The following is a description of a gene set: studied in species Homo sapiens from publication Chen Y, Wang X (PMID 31504780) Genes predicted to be targets of miRBase v22 microRNA hsa-miR-5008-5p in miRDB v6.0 with MirTarget v4 prediction scores > 80 (high confidence targets). Human Gene Set: MIR5008_5P, and this is the list of marker genes: C12orf42, ARHGAP27, ARFGEF1, PLAUR, URM1, EPB41L1, FOS, APOBR, ATXN1L, MAN1C1, PIK3C2G, KAZN, NRIP2, ALS2CL, BCL11B, FAM234A, FBXO10, CPNE5, RTP2, FOXJ2, ITPKB, ITIH4, RBM15, PRPF19, ZNF236, LUZP1, SMPD3, CDH13, NTSR1, RPS6KL1, SNX27, CTDSP2 (CTD small phosphatase 2), ATXN7, CERS2, TMCO1, JAK3, MIGA2, MYL3, HIF3A, ARRB1, DOK7, PDE2A, ABTB2, FGF12, APOBEC3D, AGAP1, CLN6, FUT5 (NCBI Gene Id 2527), NUP62, MRAP, GXYLT1, WNT7A, FXR2, CCDC40, ZHX3, OLIG3, WASHC3, ARHGEF15, S1PR4, RBP1, TMEM120B, ZEB2, RPGR, HOXC6, HSPA12B, PDE4C, HAUS4, NUDC, LINGO1, LRRC46, APOBEC3C, SMARCA2, ARAF, VPS13D, RAB11FIP4, TBL2, TJAP1, DIRAS1, SMIM8, FUT6, CFAP44, SLC22A18AS, ZNF346, ANKRD13C, SYNPO2L (synaptopodin 2 like), ENSG00000215022 (novel transcript, antisense to PHACTR1)